Given this list of marker genes Rtn2, Grb10, Crnkl1, Slc30a7, Ar, Stk3, 1110018N20Rik, Ccnl1, Pm20d1, Frmd5, Fbrsl1, Ftl1, Igfbp2, Bag5, B3gnt7, Tmem131, Nck1, Actr10, Mrpl30, Ubac1 (ubiquitin associated domain containing 1), Bzw2, Recql, Fndc3a, Cmpk1, Med25, Dcun1d4, Gm26802, Otud6b, Tmem129 (NCBI Gene Id 69753), Pomgnt2, Bcs1l, Rfx2, Wdhd1, Irgm2, Setd2, Pdik1l, Dffb, Dysf, Htt, Nfe2l1, Nr0b2, Ube3a, Lsg1, Zftraf1, Gramd1b, Gm22879 (NCBI Gene Id 115489587), Phyhd1, Neo1, Lrrfip2 (leucine rich repeat (in FLII) interacting protein 2), Comt, Lima1, Zfp830, C3, Med13l, Ttc36, Ppm1a, Pak1, Oas1c, Kdm2a, Rarg, Cnnm4, Fcor (Foxo1 corepressor), Rbm17, Macf1, Rpl31, Rmnd5a, Coa8, Tk1, Prpf4b, Rbm4b, Hnrnpl, Scp2, Zfp26, Dtx3l, Anpep (alanyl aminopeptidase, membrane), Hadha, Snrpa, Tcf12, Spmip7, Zfp142, Islr2, Pou2af3, Aars1, Lamr1-ps1, Gm5475, Mapkapk3, Eef1d, Bhlha15 (basic helix-loop-helix family, member a15), Zfp85, Slc4a3, Il24, Btf3, Ubald1 (NCBI Gene Id 69005), Crk, Trdd2, Tm2d1, Gm15535, Zfp524, Cd55, Sec22b, Cdyl2, Zmym4, Gadd45b (NCBI Gene Id 17873), Pitpnm2, Ppp4r1, Ndufaf3, Pnma8b, Myh14, Brpf1, Mier1, Snhg6, Rbbp5, Ablim1, Stt3a (NCBI Gene Id 16430), Pphln1, Zfp661, Hmbs, Pitpnm2os2, Bmpr1a (bone morphogenetic protein receptor, type 1A), Jrk, Ift172, Atp5pb, Gm16208, Omd, U2surp (NCBI Gene Id 67958), Anapc7, Cab39, Fdx1, Zc3h7b, Fam162a, Dact1, 1700030C12Rik, Akr1cl, Prkrip1, Pank1, Gm12409, Tprkb, Slf2, Mbd1, 1500002F19Rik, Mir503hg, Cfap221, Ccdc9, Hmgb1, Bhlhe40, Ccdc57, Gm27021, Sulf2 (sulfatase 2), C1rb, Sergef, Rab28, Pik3r3, Crls1, Kifc5b, Csnk1g1, Spag6, 1700041G16Rik, Cbfb, Zfp335, Inpp5b, Nsa2, Sorbs3, Smarce1, Mtmr2 (myotubularin related protein 2), Mirlet7i, Rab35, Ube2e2, Axin1, 6030445D17Rik, C030037D09Rik, Homer2, Mir7238, Zfp865, 1110025M09Rik, E330017L17Rik, Atxn7l2, L3hypdh, Mir2861, Cspg5, Taf8, Ddx54, Slc25a27, Oasl1, Dop1a, Arrdc1, Gm25280, Zfp667, Rapgef3, Tapt1, Cox5a, Adgrl1, Rock1, Wasf2, Coro1a, Dnajc11, Pip4k2b, Fam53c, Cep70, 3110056K07Rik, Fbxl18, Cox20, Stk11ip, Pdk4, Atp1b3, Faah, Tfdp1 (transcription factor Dp 1), Ddx18, 4930597O21Rik, Nt5m, H3c11, Tbx3os1, Mnat1, Mia3, Gm40123, Slc25a29, Cep131, Wdsub1, Cbfa2t3, Ccdc60, Qki, Pcdh18, Megf8, Bltp2, Fbxo42, Ppp5c, Etv4, Nxpe3, Gm13161, Gstp3, Esf1 (NCBI Gene Id 99391), Arv1, Gm12063, Map3k8, Fxyd1, Ccn4, Gm28857, Qrsl1, Zfp652, Tcf4, Commd10, Pfkfb3, Slc24a3, Itgb3bp, Dhps, Or4f54, Ric8b, S100a10, Rnf44, Rps13-ps5, Cutc, Kcnh2, Nup54, Vdac2, Ism1, Prss57, Fbxl5, Mmp16, Klf7, 2310043M15Rik, Tbxas1, Kmt2c, Srsf3, Klhl18, Gipc1, Dbil5, Golt1b, Mybl1, Efcab2, Arrdc5, Ccni, Gm15567, Gpr173, Grm4, Cenpu, Gm30238, Usp32, Lmo4, Enho, Spcs3, Plekha7, Trappc8 (trafficking protein particle complex 8), Atp2a2, Zbtb7c, Gm15927, Tatdn1 (NCBI Gene Id 69694), Kif9, Snrpg, Uqcrc1, Pemt, Ddb2, Mir320, Zfas1, Trappc2b, Kcng4, Slc25a10, Wsb2, Vsig10, Rpl36a, B9d1os, Ablim2, Ep300, Ttc13 (tetratricopeptide repeat domain 13), Pkdcc, Zfp641, Rapgef2, Cul2, Gm16675, Cln8, Crat, Ube2v1, Thra (NCBI Gene Id 319227), Nudt3, Lamtor1, Gemin4, Coq9, Mrps11, Cryz, Gm10433, Frmd6, Sytl4, Slc25a36, Znfx1, 4930592C13Rik, Gm14022, Tor1aip1, H1f3, H4c1, Nop9, 1700096K18Rik, Ubb, Gm11765, 9130604C24Rik (NCBI Gene Id 77707), Hoxc12, Lasp1, Cerk, Plekha6, 5031425E22Rik, Ift22, Gatb, Kctd13, Mitd1, Rtn4ip1, Gm15541, Cyth1, Armc8, Zfyve21, Ywhab, Hmgxb4, Prkce (NCBI Gene Id 98094), Srcap, Nat8f1, Mir1953, Dhx58, Gm9828, Cyp17a1, Kank1, Wbp4, Vps35l, Supt7l, Smim1, Mir450-2, Pfkp, Snord38a, Lbp, Krt79, Als2cl, Srsf2, Timm8b (translocase of inner mitochondrial membrane 8B), Dph6, Ptp4a1, Lrpprc, Slc4a1ap, Pknox1, Mbd5, Nupr2, Mcts1, Sypl1, Sh2b3, Plk3, Lrrc24, Tspan2, Spink13, Extl2, Palmd (palmdelphin), Elp1, Furin, Psip1, Fam53b, Mtch2 (NCBI Gene Id 80443), Zfp646, Eef2, Lrrk2, Sv2b, Steep1, Kif16b, Gm9687, 4933406C10Rik, Trabd2b, Macroh2a1, Chd6, Myl12b, Irf9, Itch, Peak1, Eif5a, Camta1 (NCBI Gene Id 75679), Myef2, Patz1, Atp2a3, Sertad2, Mrpl55, Gm13286, Nedd4, B3gnt8, Rps23, Gin1, Gm22353, Sptbn4, Dlst, Tut7, Jsrp1, Trim16, Fuca2, Tmem164, 1700016A09Rik, Ppp3cc, Atoh8, Acap3, Ttk (Ttk protein kinase), Zfp672, Fkbp5, Map3k1, Capn5, Sfpq, Sos2, Bsg, Fmc1, Tmem143, Mcm5, Car7, Hook3 (hook microtubule tethering protein 3), Nrn1, Chd1, L3mbtl3, Fzd10, Gm12930, Taf1a, Stom, Sap30bp, Mlh1, Slc45a4, Paox, Frat2, Ndufaf4, Pop5, Zfp740, Arih1, Hoxc10, Grk6, Parp14, Ube2f, 4930509H03Rik, Ift52 (NCBI Gene Id 99173), Gm43403, Dock5, Dnal1, Ccne2, Mtbp, Sf3b4, Nfat5 (nuclear factor of activated T cells 5), Snord59a, Slc19a2, Mir450b, Cbfa2t2, Gsg1l, Map10, Cip2a, Zfp493, Prune2, Fhod3, Bmp2k, Casp9, Zfp746, Cdk9, Kcnt1, Whamm, Rps14 (NCBI Gene Id 99773), Numb, Csnk1d, Arhgap11a, Plekhg2, Limk1, Gm26160, Rpl7a, Setdb1, Acp1, Mrpl46, Col15a1, Def8, Slc9a1, Tceanc, Suv39h2, Lsm5, Rrn3, Pdcd4, Kat6a, Ciao3, A830008E24Rik, Lhx1, Setbp1, Mettl17, Src, Ccnq, Mpzl3, Sox7, Igsf5, Trabd, Rgp1, Gm22980, Zhx2, Eif3c, Topbp1, Wars2, Atg16l2, Kmt2e, 1700052K11Rik, Tnik, Plk2 (NCBI Gene Id 20620), Csk, Acad11, Mgat5, Mbnl1, Zfp639, Nol7, Ankrd37, Dnaaf5, Bloc1s2, Il3ra, Nlrp10, Supt20, Zfand2b, Mir7672, Taok3, Fgf9, Sema4b, Tmie, Slc22a5, D330041H03Rik, Hspa4, Ndufb4, Msrb2, Tmem161a, Ppp2r5c, Srm, Lrp1, Lgr6, Col6a1, Nbas, Zbtb25, Fblim1, Dzip3, Septin7 (septin 7), Tardbp, Pmp22, Mtrr, Wdr13, Gm2a, Taf9, Pycr2, Lrch4, Vamp1, Cir1, Aftph, Npepl1, Zfp54, Gm15327, Ssbp2, Pde10a, Zcrb1, 1700008J07Rik, Clec2d, Pyroxd2, 9130401M01Rik, Nt5c, Prkar1b, Slc25a42, Gtf2ird1, Spin1, Gm20652, 2200002D01Rik, Kctd14, Med4, 4930412C18Rik, Nenf, Ccdc191, Top3b, Col8a2, Txndc2, Camk2g, Npm1, Hmgb3, Efr3a, Cplane1, Wtap (WT1 associating protein), Cul1, Ndufs5, Arid4a, Pusl1, Cep57, Fbxo21, Elovl6, Vgll4, Klf16, Dennd1b, Gm11816, Arl15, Igsf3, Ptpa, Ighmbp2, Pcif1, Trim41, Bean1, Zscan25, Thbs2, Sash1, Wdfy1, Zfp106, Lars2, Cox7c, Nrbp1, Rai14, Csdc2, Fzd4, Sh3bp4, Tmem98, Adh5, Degs1, Depdc7, Prdm16, 5330439K02Rik, Zdhhc23, Mexis, Shroom3, Slc35f6, Rab27a, Slc25a5, Jak1 (Janus kinase 1), Abca5, Prkci, Pgm5, Cacng3 (NCBI Gene Id 54376), Poli, Tpbg, Gask1a (golgi associated kinase 1A), Katnbl1, Ppp4r1l-ps, Ndufs1, Nme5, Atp5f1b, Drap1, Mfsd11, E130311K13Rik, Ttll10 (NCBI Gene Id 75376), Zfhx2, Glis3, Fndc7, Adcy5, Crim1, 3010001F23Rik, Ppp2r2d, Klf13, Acacb, Camk2n1, Cox8b, Lgi4, Zgrf1, Srebf1 (sterol regulatory element binding transcription factor 1), Gm12339, Yju2, Dicer1, Atpsckmt, Krr1, Akr1b7, Satb2, Rrp7a, Dand5, Tnks1bp1, Cul4b, Mgat4b, Nme4, Nfia, Znrf1, Clspn, Dgcr6, Sla, Bzw1 (NCBI Gene Id 66882), Cdk15, Stox2, Sh3yl1, BC025920, Osbpl7, Pate2, Arhgap22, Phf8 (NCBI Gene Id 320595), Smad2, Gm4575, Scarna17 (small Cajal body-specific RNA 17), Slc35e2, Rai2, Sftpb, Kdm2b, Me3, Blcap, 9330111N05Rik, Dph3, Spop, Tpm3, Ccdc88a, Mn1, 1700001D01Rik, Mboat2, Tle1, Sufu, Tctn1, Gnb1, 2310001H17Rik, Mpc1, Rnf217, Zfp3, Blvrb, Mtfr1l, Ano6, Nr2f2 (NCBI Gene Id 67192), Pomt1 (NCBI Gene Id 99011), Yap1, Lrp11, Zfp879, Rbpms2, Zbtb24, Hoxb6, Brd2, Eif3g, Usp14, Ndufaf5, Wdr20, Kank3, Ech1, Tonsl, Snord35b, Ermp1, Etv1 (NCBI Gene Id 14009), Klf3, Hmg20b, Shq1, 6030442K20Rik, Armcx5, Aplp2, Ints10, Rictor (NCBI Gene Id 78757), Mpp3, Chmp3, Syt17, Ndufa4, Mir1960, Large1, Ccng2, Gorab, Maea, Tbc1d9b, Rad54l2 (NCBI Gene Id 81000), Txn1, Gm16168, Ndufc1, Aldh4a1, Zfp354a, Fam161a, Aph1a, Gpx8, Thoc2, Slbp, Cox8a, Tomm40, Pex13, Tmem135, Kif11, Rps17, Hoxb4, Cep63, Ncapd2, Gins1, Kcnb1, Ppp1r12b, Actr5, Trdmt1, E230013L22Rik, Serinc3, Gart, Tmem82, Abca4, Cdhr17, Atg10, 9630001P10Rik, Hnrnpa0, Taf6l, Mir8101, Gm24134, Gm32950, Dcbld2, Nmrk1, Ivd, Tcp11l1, Rxra, Eif5, Fam120a, Garre1, Tmem120b, Gm26725, Pan3, Zbtb2, Ythdc1, Mfap1b, Acaa2, Atp5mg, Helb, Gm24355, Rps19bp1, Larp7, Rbm25, Peg13, Sugct, Zfp644, Gm10555, Gdi1, Mir219c, Tagln, Mindy2, Asap1, Cfap61, Retsat, 4930527J03Rik, Naif1, Mtus1, Rbpj, Mrpl21, Jam2 (NCBI Gene Id 76825), Alkbh3os1, Gm15787, Pabpc4l, Gabpb1, Unc13d, Mlst8, Zfp994, Zcchc14, Mir450-1, Zfp704, Cmss1, Luc7l2, Zrsr2, Sipa1l3, Rnf14, Fuom, Tanc1, Mapk1ip1, Elmod3, Zeb2os, Osbpl2, Ctbp2, Plac8, Mir99ahg (Mir99a and Mirlet7c-1 host gene (non-protein coding)), Gpx4, Cacnb2, Ppp2r2a, Hbs1l, Gsn, Mir7039, Piga, Dennd6b, Apbb2 (amyloid beta precursor protein binding family B member 2), Homer1, Xpo1, Stard9, Gpatch2, Fiz1, Aff1, H2-K1, Tarbp2, Tmem43, 2810021J22Rik, Dennd2c, Pex2, Sh3bp5l, Man2c1 (NCBI Gene Id 73744), Rpl22l1, Depdc5, Exoc3, Prkn, Ube2a, Atxn2l, Pkig (protein kinase inhibitor, gamma), Hectd1, Gprasp1, Tpgs1, Gsta3, Prkar1a, Prex1, Letmd1, Pex19, Ppip5k2, Irf8, Gm23119, Ptgr3, Mir5122, Anxa2, Kdm3a, Snora26, Rps8, Mir345, Car2, Mir7687, Rcbtb1, Snx15, Ankrd16, 2610507I01Rik, Gm15558, Tbc1d15, Ino80dos, Med15, Fam210a, Gm15952, Gng8, Cpeb3, Slc44a1, 1810064F22Rik, Rnf103, Pygb, Ogfod2, Zbtb18, Gm35986, Gm5532, Mtfr1, Zbtb20, Nelfb, Mrpl15, Man2c1os, Cc2d1b, Rbm26, Gpr20, Klhdc10, Cenpa, Gm6967, Lamc2, C330013E15Rik, Mdn1, Mtnap1, Zfp560 (zinc finger protein 560), Alkbh7, Atp1b2, Midn, Snhg5, Gm13974, Prkag2, Lamb2, Gm10941, Nwd1, Gm1720 (predicted gene 1720), Mob1a, Vps26b, Ift88, Nek4, Esrra, Pde3a, Sppl2a, Gm26766, Cmip, Gm2559 (predicted gene 2559), Gm20517, Pag1 (NCBI Gene Id 94212, phosphoprotein associated with glycosphingolipid microdomains 1), Nsf, Sfmbt1, Prkdc, Zfp143, Akr1a1 (aldo-keto reductase family 1, member A1), Zfp383, Cbx2, Pigb, Ubqln1, Wdr75 (WD repeat domain 75), Rps15a (NCBI Gene Id 319296), Kcnj2, Zfp146, Gm5069, Kmt5b, 1110032F04Rik, Gm43649 (predicted gene 43649), Sgms1, Nr3c1, Gm25628, Tacc3, Gm6410, Rab11fip2, Psma7, Pfn2, Got1, Irf3, Mypop, Dock7, Washc4, Nup133, Fosb, Gm6712, Tesk1, Plpp7, Lrp12, Slc6a16, Ssr2, Abraxas2, Rhobtb1, Hdac2, D630039A03Rik, Pgam1, Efcab7, Gm13049, Ccdc80, Gm15704, Meak7, Chmp1a, Ak6, Cntln, 2010109A12Rik, Gtf3c5, Mrps5, Casq2, Slc38a6, Slc52a2, Pabir1, C430014B12Rik, Slc4a8, Slc25a25, Ube2m, Bmper, 4732440D04Rik, Stxbp5, Mrpl13, Aqp7, Ralgds, 9430002A10Rik, Anapc13, Trp53cor1, Kpna2, Scn2a, Pias2, Vps13d, Abi2, Gm16001, Alyref2, H2ac20, Syvn1, Smim8, A530064N14Rik, Tdp2, Zfp184, Fbxl12os, Oser1, Phf5a, Slc25a12, Tob2, Ccdc77, Fanci, 4933400C23Rik, Zdhhc14, Taf1b, Sypl2, Atad2, Banf1, Arid1a, Gm27003, Nr2f6, 8030451A03Rik, B3galnt2, Cenpn, Ndufa10, Septin12, Polr1g, 4833445I07Rik, Asb16, Ppih, Gm7626, 1810021B22Rik, Asf1a, Gls, Tmem11, Prkx, Ring1, Pmepa1, Eef2k, Tppp3, Med20, Rassf5, Tigd3, Trappc12, Rnf157, Slc35b1, Abhd13, Thrb, Zfp809, Nsfl1c, A830082K12Rik, Emc6, Fam193a, Rbbp7, Ahsa2, Tanc2, Foxo4, Mfsd2a, AY512915, Rnf170, Cyfip1, Golga3, Anapc5, Poc1a (POC1 centriolar protein A), Fn3k, Zfp933, C1qbp, Ctnna3, 4933421A08Rik, Msi2, Dnajb6, Casp2, Pon3, E330013P04Rik, Tnip1, Btg3, Map4, 2300009A05Rik, Esco2 (NCBI Gene Id 71988), Kdm5a, Hdac5, Ciapin1, Pola2, Amz2, Ypel1, Polr3d, Cdk5rap2, 4930579G24Rik, Mir5625, Cldn12, Ppp2ca, Esr1, Lrp6, Unkl, 4930401G09Rik, Dancr, Gm14066, Tmem67, Ccdc8, Gata4, Glcci1, Luc7l, Tcf7l1, Mir6944, Mir100hg, Ttc39aos1, Gemin7, Apba1, Rgs3, Pgp, Ddx23, Gtf3c4, Wdr18, Dtd2, Pepd, Tmem242 (transmembrane protein 242), Rnf7, Carmil1, Evx1, Mtrf1l, 2900052L18Rik, Ndufs6b, Sdhd, Gid8, Ago2, Snora24 (small nucleolar RNA, H/ACA box 24), Grik5, Hspa9, Lsm11, Mfsd5, Slc25a28, Fis1, Gfm2, Srsf6, Fus, Cacna1h, Snrnp35, Chn1, Tmem68, Cacna1c, Myo1h, Zeb2, Dnali1, Prkd3, Cers5, Fabp3, Rpia, Klhdc2, 4930432B10Rik, Rel, Polr2m, Eno1, Mapk4, Mir7056, Fance, Mir3960, Agk, Rps5, Entrep1, Tbata, Acsl1, Lifr, Fgfr4, Pabpc1, Hexd, 2410017I17Rik, Sgo1, Ing2, Arhgef40, Rap2a, Tcf3, Gtpbp2, Smc3, Rnmt, Chfr, Gm17102, Psme1, Acss1, Aak1, Amot, Kif7, D16Ertd472e, 1700120B22Rik, Cox17, Qtrt2, Hsp90ab1, Elf1, Mir7671, Gm16083, D5Ertd579e, Spats1, Uck1, Zfand5, Galnt17, Gm24998, Fkbp8, Atrx, Tet2 (tet methylcytosine dioxygenase 2), Abhd3, Nfyb, Mkrn2, BC004004, Dedd, Gpc4, Trpm7, Dab2, Rdh5, Vangl2, Clip1, Gpn3, Uba5, Acin1, Tmod2, Pmepa1os, Dnai4, Fbxo32, Gm9968, Zfyve27, Cul4a, Tsbp1, Lrig2, Ndufa12, Paxip1, Rnf220, Lrfn4, Ndfip2, Adamts1, 9930004E17Rik (RIKEN cDNA 9930004E17 gene), Pcid2, Aco2, Ppp2r5b, Tmem199, Zbtb10, Vti1b, Pbx3, 4930563E18Rik, Gps2, Uqcc3, Snrpd3, Fkbp2, Memo1, Brpf3, Mrpl1, Rassf8, Rad51, Hpgd, Sirpa, Ocel1, Snip1, Txnrd2, Arf6, Fbxo33, Rhbdd2, Mcm4, Morc4, Edrf1, Pdgfd, Xab2, Socs2, Adat1, Gm11936, Gm15320, Frmd4a, Rbm15b, Plxnd1, Trip4, Ctsl, Rad17, Rb1cc1, Dhx35, Abhd16a, Mdc1, Fhl4, Larp4b, Cdc42bpa, Heph, Ptprr, Cdc42ep5, Cyp2u1, Ephb2, AA474408, Lims1, Mplkip, Hs6st1, Fastk, Hspb2, Zfp668 (zinc finger protein 668), Tfrc, Ube2s, Tfap2c, Pdzd7, Cers6, Ddx31 (NCBI Gene Id 227674), Srsf1 (serine and arginine-rich splicing factor 1), Rxylt1, Gns, Usp3, Actr1a, Ube2d2a, Lrrc71, Tvp23bos, Tnfaip8, Zfp236, Gm16364, Mrpl3, Ap1g1 (NCBI Gene Id 52301), Slc39a1 (solute carrier family 39 (zinc transporter), member 1), Cyp39a1, Ss18l1, Cluh, 1500012K07Rik, C920021L13Rik, Klhl21, Mterf3, Rabep2, Nol12, Pgbd1, Gm5113, AI987944, Zbtb11, Itsn1, Mri1, Klf4, Tmem176a, Mrpl54, Pfdn4, Zfhx3, Hnrnpul1 (heterogeneous nuclear ribonucleoprotein U-like 1), Eed, Sephs1, Wnt5b, Slc25a53, Bin3, Etf1, Tgs1, Hipk3, Mob4, Pym1, Hsd17b12, Tmeff1, Coa6, Galnt10, Mthfd2l, Orc4, Cpd, Ptger1, D17H6S53E, Wdr33, Rpl29, Tmem217, Hras, Gas7 (NCBI Gene Id 320013), Nat8f4, G3bp2 (NCBI Gene Id 319444), Zranb2, Ifitm10, Scaf8, Ccnjl, Gm20605, Qrich1, Ttc39d, Mir3071, Cfap43, Ybx2, Tmed2, Osbp, Akr1b10, Rapgef4 (Rap guanine nucleotide exchange factor (GEF) 4), Kif22, Ankrd10, Otud7b, Dab2ip, Vmn2r-ps19, Gm25794, Slc16a5, Ppara, Aste1, Cmc2, Axin2 (NCBI Gene Id 12006), Eif1ad, Kif13a, Ddost, Map3k9, Sp3, Entpd5, Mir3091, Rps21, Bcl2l12, Zbtb44, Cd99l2, Gkap1, Mllt3, Oxsm, Sh2b1, Hmg20a, Gm22748, Mrps21, Rnls, Numbl, Slc25a39, Pus10, A430035B10Rik, Lig4, Gm12925, Klhl23, Rpp30, Azin1 (antizyme inhibitor 1), Arrb2, Bend3, Nadk, Snx19, Rdh13, Gm25878, Gfpt1, Gm10638, Rps7, Son, Snhg8, Mir7115, Prrx1, Smim27, Phip, Pcmt1, Gm16144, Nmral1, Mef2c, Pex11b, Pacrg, Myl12a, Gm16759, Them6, Cep68, Irs1, Arhgef10, Cltc, Ppm1k, Pttg1, Tex30, Sucla2, Set, Arhgef2, Timm22, Pdcl, Ankrd13c, Mef2a, Cfl2, Pitpnc1, Slc11a2, Rnf20, Ppp1r13l, 2700099C18Rik, Krcc1, Myc, Pdpr, Col6a2, Rela (NCBI Gene Id 19697), Ramp2, Sfxn4, Chchd7, Zfp618, Nfix, Gucd1, Gm13822, Fastkd3, Gde1, Prickle1, Ttc39a (tetratricopeptide repeat domain 39A), Tmem176b, Rpl7, Tmbim1, Lmntd1, Pkia, Otulin, Calm3, Aar2, Med22, Gigyf2, Nfxl1, Ddx59, Klc4, Shoc2, Pik3cd (phosphatidylinositol-4,5-bisphosphate 3-kinase catalytic subunit delta), 4930512B01Rik, Rpa2, Slc38a9, Acadl, Emc8, Fancc, Abitram, 6030442E23Rik, Gba2, B9d1, Smg1, Ywhah, Zfp946 (NCBI Gene Id 74149), Cyp4f14 (NCBI Gene Id 80440), Dcun1d1 (NCBI Gene Id 114893), Gm9515, Kxd1, Dctn6, Kif3b, Spata17, Cct5 (NCBI Gene Id 12465), Gstt2 (glutathione S-transferase, theta 2), Cdkn2c (cyclin dependent kinase inhibitor 2C), Eef1b2, A930024E05Rik, Mrps28, Lnpep, Zbtb7b, Taf4b, Tmem87b, Pds5a, Inpp5a, Rbm47, Grwd1, Ergic1, Riok1, Zfp9, Osbpl1a, 2610306M01Rik, Pde4d, Zdhhc17, B230206L02Rik, Npr1, BC043934, Ankrd13a, Rnf6, Iqsec1, Tspan9, Rita1, Zyg11b, Gng12, Armcx2, Ndufb9, Hivep1, 3300002A11Rik (NCBI Gene Id 72601), Soat1, Fkbp3, Asnsd1, Letm1, Fan1, Hsf3, Arhgap42, Phf14, 2410022M11Rik, Gpr180, here is a description of the gene set: Mouse Gene Set: NR5A1_TARGET_GENES studied in species Mus musculus Genes containing one or more binding sites for (Nr5a1) in their promoter regions (TSS -1000,+100 bp) as identified by GTRD version 20.06 ChIP-seq harmonization. from publication Yevshin I, Sharipov R, Kolmykov S, Kondrakhin Y, Kolpakov F (PMID 30445619)